Given this list of marker genes C4a, Ptx3, C4b, Cd93 (NCBI Gene Id 99415), Calr, Apcs, Mptx1, Megf10, Crp, C1qbp, Mptx2, here is a description of the gene set: studied in species Mus musculus Binding to a C1q complex, a component of the classical complement cascade. Mouse Gene Set: GOMF_COMPLEMENT_COMPONENT_C1Q_COMPLEX_BINDING